The following is a description of a gene set: Tryptophan metabolism Human Gene Set: WP_TRYPTOPHAN_METABOLISM studied in species Homo sapiens, and this is the list of marker genes: IDO2, IDO1, KYAT1, HADH, DDC, ACAT1, ACMSD, IL4I1, ASMT, AHR, KYAT3, ECHS1, STAT1, ALDH8A1, MAOA, TDO2, CAT, TPH1, TPH2, DLD, GOT2, KMO, AANAT, CYP1A1, AADAT, AOC1, INMT, AOX1, KYNU, GCDH, AFMID, ALDH2, HAAO